Given this list of marker genes SKP1, PSMD6, PSMC1, PSMA5, PSMB3, PTK6, SEM1 (SEM1 26S proteasome subunit), PSMD8 (NCBI Gene Id 5714), RPS27A, PSMA6, PSMC4, PSMC2, PSMD2, PSMD12, UBC, ADRM1, PSMB6, PSMD14, CDKN1B, PSMB1, CUL1, CCNA1, PSMA2, PSMD1, PSMB4, CCND1 (NCBI Gene Id 893), CCNE1, CCNA2, SKP2, CDK2, CCNE2, PSMA7, CDKN1A, PSMD7, UBB, PSMC6, PSMD11, PSMC3, PSMA1, PSMB7, CDK4, CKS1B, PSMB5, PSMD13, PSMA3, PSMB2, PSMD3 (proteasome 26S subunit, non-ATPase 3), PSMC5, UBA52, PSMA4, here is a description of the gene set: species: Homo sapiens During G1, the activity of cyclin-dependent kinases (CDKs) is kept in check by the CDK inhibitors (CKIs) p27 and p21, thereby preventing premature entry into S phase (see Guardavaccaro and Pagano, 2006). These two CKIs are degraded in late G1 phase by the ubiquitin pathway involving the ubiquitin ligase SCF(Skp2) and the cell-cycle regulatory protein Cks1. Recognition of p27 by SCF(Skp2) and its subsequent ubiquitination is dependent upon Cyclin E/A:Cdk2- mediated phosphorylation at Thr 187 of p27. There is evidence that Cyclin A/B:Cdk1 complexes can also bind and phosphorylate p27 on Th187. Degradation of polyubiquitinated p27 by the 26S proteasome promotes the activity of CDKs in driving cells into S phase.. The mechanism of SCF(Skp2)-mediated degradation of p21 is similar to that of p27 in terms of its requirements for the presence of Cks1 and of Cdk2/cyclin E/A (Bornstein et al.,2003; Wang et al., 2005). In addition, as observed for p27, p21 phosphorylation at a specific site (Ser130) stimulates its ubiquitination. In contrast to p27, however, ubiquitination of p21 can take place in the absence of phosphorylation, although with less efficiency (Bornstein et al.,2003). SCF(Skp2)-mediated degradation of p27/p21 continues from late G1 through M-phase. During G0 and from early G1 to G1/S, Skp2 is degraded by the anaphase promoting complex/Cyclosome and its activator Cdh1. The tight regulation of APC/C(Cdh1) activity ensures the timely elimination Skp2 and, thus, plays a critical role in controlling the G1/S transition. APC/C(Cdh1) becomes active in late M-phase by the association of unphosphorylated Cdh1 with the APC/C. APC/C(Cdh1) remains active until the G1/S phase at which time it interacts with the inhibitory protein, Emi1. Inhibition of APC/C(Cdh1) activity results in an accumulation of cyclins, which leads to the phosphorylation and consequently to a further inactivation of Cdh1 at G1/S. Finally, to make the inactivation of APC/C(Cdh1) permanent, Cdh1 and its E2, namely Ubc10, are eliminated in an auto-ubiquitination event. At G1/S, Skp2 reaccumulates as Cdh1 is inactivated, thus allowing the ubiquitination of p21 and p27 and resulting in a further increase in CDK activity. Reactome Pathway: SCF(Skp2)-mediated degradation of p27/p21 part of: Cyclin A:Cdk2-associated events at S phase entry; Cyclin E associated events during G1/S transition 